Given this list of marker genes NHERF1, MEN1, ABCC6, SLC34A1, INPPL1, ATP7B, ALDOB, CASR, PTH1R, KRAS, MT-TN, PHEX, COA8, GATM, HRAS, HNF4A, ENPP1 (ectonucleotide pyrophosphatase/phosphodiesterase 1), OCRL, CTNS, FAM20A, DMP1, CDC73, CLCN5, GNAS, GCM2, EHHADH, SLC34A3, NDUFAF6, CYP27B1, NRAS, FGF23, SLC2A2, SURF1, here is a description of the gene set: species: Homo sapiens Human Gene Set: HP_ABNORMAL_URINE_PHOSPHATE_CONCENTRATION An abnormal phosphate concentration in the urine. Abnormal urine phosphate concentration